The following is a description of a gene set: Human Gene Set: MIR504_3P Genes predicted to be targets of miRBase v22 microRNA hsa-miR-504-3p in miRDB v6.0 with MirTarget v4 prediction scores > 80 (high confidence targets). from publication Chen Y, Wang X (PMID 31504780) species: Homo sapiens, and this is the list of marker genes: CREBRF, ACTR5, ATF7 (NCBI Gene Id 11016), PDZD2, SLC35E3, LRRC74B, ORAI2, CCDC142, OCRL, LPCAT3, IVD, CDKN2AIPNL, CHST15, KCNN3 (NCBI Gene Id 95947), SPTY2D1, MSRB3, LRRTM2, RBFOX1, PBOV1, C3orf62, MPV17, RBM48, EEIG1, POLH, NKAIN2, MFSD11, HOXD1, ZFP14, RAVER1, GLUL, ZNF135, CLN8, TFDP2, SUSD6, VPS26A, GYS1, DCAF10, LDLRAD1, DSTYK, MARVELD3, VHL, NCAPD2, WDR47, UPK1B, XIAP, GJC1, RFC2, ARSA, EIF3I, ZNF483, ZNF431, SMYD4, COG5, RBM47, CHRNA5, TRPS1, CA10, SEC14L4, NLN, BPHL, ABR, ITIH5, TPRG1L, TBL1XR1 (TBL1X/Y related 1), KIF1B, NOCT, CCDC157, ATP5MF-PTCD1, CYP20A1, ZNF106, PDE4C, EPCIP, DUSP18, DNAJC18, KLK10, STK38L, DDR2, TRIM56, FAM227A, ASCL1, PNPT1, DENND2A, TSPAN6, ZBTB8A, DNAJB7 (NCBI Gene Id 150353), CMKLR2, PAMR1, NMNAT1, CRCP, TMEM201, ABHD18, PTCD1, MTG2, ZNF540, HNRNPU, WDR93, PDP2, ZKSCAN1, GRB10, MGP, RPL7L1, NABP2, PTPN2, SLC31A1 (NCBI Gene Id 1317), PRR11, G6PD, SMIM14, VAMP3, ING3, MED29, ERBB4, THG1L, ZNF430, KCP, RIPOR2, TIMM50, MYH11 (myosin heavy chain 11), CWF19L1, OTUD6A, PHACTR4, AVIL, PURB, ZNF213, IFITM1, MOSPD1, LRRC2, ZNF829, LYRM7, RAD1, TECTB, BHLHE41, AARS2, NOS1, DBT, MIGA1, MAP3K3, LINC02908, ADAMTS15, BCAS1, CCDC90B, SERF2, P4HA1, SLC43A2, ZFP82, TMC7